The following is a description of a gene set: Any process that modulates the frequency, rate or extent of T-helper 2 cell differentiation. studied in species Mus musculus Mouse Gene Set: GOBP_REGULATION_OF_T_HELPER_2_CELL_DIFFERENTIATION, and this is the list of marker genes: Prkcz, Il4ra, Ascl2, Irf1, Hlx, Anxa1, Tnfsf4, Socs5, Il6, Bcl6, Nlrp3, Zfp35, Il18, Rara